The following is a description of a gene set: Genes up-regulated in comparison of B cells versus monocytes. Systems vaccinology has emerged as an interdisciplinary field that combines systems wide measurements and network and predictive modeling applied to vaccinology. Here we used the systems vaccinology approach to study the molecular mechanisms underlying th from publication Nakaya HI, Wrammert J, Lee EK, Racioppi L, Marie-Kunze S, Haining WN, Means AR, Kasturi SP, Khan N, Li GM, McCausland M, Kanchan V, Kokko KE, Li S, Elbein R, Mehta AK, Aderem A, Subbarao K, Ahmed R, Pulendran B (PMID 21743478) studied in species Homo sapiens Human Gene Set: GSE29618_BCELL_VS_MONOCYTE_UP, and this is the list of marker genes: IGKV1D-13, BACH2, PTPRCAP, PKIG, C10orf95-AS1, ZNF93, CXCR4, SYNPO, GOLGA8A, CERNA1, BACE2, PPP1R16B, TCF3, BTG1, ANKRD12, H2BC9, CDK14, DDX6, ATP2A3, CBLB, LTB, P2RX5, IL4R, NUP88, RRAS2, AQP3, RPS6 (ribosomal protein S6), RASGRP1, CD69, SPTBN1, AFF3, IGKC, RPS27A, FCER2, SEL1L3, PALS2, PRKACB, PHF1, DZIP3, BANK1, HLA-DOA, LUC7L, STAG3, ANKRD36, TRBC1, RABEP1, IGLL3P, ATM, ABLIM1, RPS23, SIPA1L3 (NCBI Gene Id 23094), TMEM243, POU2AF1 (POU class 2 homeobox associating factor 1), RASGRP3, ETS1, ADAM28, CXCR5, KCNA3, ZNF253, SHMT2, NT5E, CD79A, CD47, CCNYL7 (NCBI Gene Id 100419017), NCK2, ABCB4, TSPAN13, FCRL2, IGHD (immunoglobulin heavy constant delta), CD37, PAX5, PPIG, ZNF675, ZNF43, CCR7, PPP3CC, H2BC12L, RUBCNL, LBH, H2BC5, BCL2, CHMP7, RASGRP2, BCL7A, PDLIM1, S1PR1, COBLL1, SWAP70, ST6GAL1, RAB30, ISG20, FAM30A, MS4A1, IGHG1, CSNK1G3, TNFRSF13B, EZR, ADD2, ODC1, SLC38A1, H4C3, MMD, HLA-DOB, TAF1D, CKAP2, DDX24, ZNF107, IFT57, TLE1, BLNK, NGLY1, GUSBP11, CD22, PCDH9, BBIP1, EIF2AK3, DDHD2, BIRC3, PIM2, MAP4K1, PWP1, SH3BP5, SYPL1, GGA2, RPLP0, IGHM, JCHAIN, PNOC, ADAM19, AEN, IGKV4-1, SLC25A4, RPSA, CD19, DENND5B, PRDM2, PIK3C2B, GABPB1, COL4A3, QRSL1, IL24, TCF4, PIKFYVE, IGLJ3, H2BC6, RPS12, BMS1P20, TSC2, CYFIP2, PHTF2, CD72, SP140, ZHX2, GOLGA8B, E2F5, ARPP19, MYC, BCL11A, CHD7, TMEM156, EVL, ARHGAP25 (Rho GTPase activating protein 25), PARP1, GNG7, ARID5B, SEPTIN6, IGKV3-20, PLCG2 (NCBI Gene Id 5336), FAM3C, TRIB2, SINHCAF, TRAF5, SLC35F2, IGLV1-44, SLC2A1, ESF1, P2RY10, STK17A (serine/threonine kinase 17a), H2BC7, CD24, FCMR, CCR6, CD79B, OGA, RPS5, CLEC2D, TENT5C, TPD52, SNRNP70, USP6NL, NOC3L, KLF8, STAP1, RPS20 (NCBI Gene Id 6224), ATP8A1